The following is a description of a gene set: from publication Bucasas KL, Franco LM, Shaw CA, Bray MS, Wells JM, Niño D, Arden N, Quarles JM, Couch RB, Belmont JW (PMID 21357945) Human Gene Set: BUCASAS_PBMC_FLUARIX_FLUVIRIN_CAUCASIAN_MALE_AGE_18_40YO_HIGH_RESPONDERS_1DY_3DY_POSITIVE_PREDICTIVE_OF_TITER BACKGROUND: Annual vaccination is the primary means for preventing influenza. However, great interindividual variability exists in vaccine responses, the cellular events that take place in vivo after vaccination are poorly understood, and appropriate biomarkers for vaccine responsiveness have not been developed. METHODS: We immunized a cohort of healthy male adults with a licensed trivalent influenza vaccine and performed a timed assessment of global gene expression before and after vaccination. We analyzed the relationship between gene expression patterns and the humoral immune response to vaccination. RESULTS: Marked up regulation of expression of genes involved in interferon signaling, positive IL-6 regulation, and antigen processing and presentation, were detected within 24 hours of immunization. The late vaccine response showed a transcriptional pattern suggestive of increased protein biosynthesis and cellular proliferation. Integrative analyses revealed a 494-gene expression signature--including STAT1, CD74, and E2F2--which strongly correlates with the magnitude of the antibody response. High vaccine responder status correlates with increased early expression of interferon signaling and antigen processing and presentation genes. CONCLUSIONS: The results highlight the role of a systems biology approach in understanding the molecular events that take place in vivo after influenza vaccination and in the development of better predictors of vaccine responsiveness. studied in species Homo sapiens Genes positively correlated with titer response index in peripheral blood mononuclear cell in Caucasian male adults (18-40) (high responders) after exposure to Fluarix/Fluvirin, time point 1D and 3DY. Comment: Signature predictive of titer response index (TRI). Day 1 and day 3 values averaged., and this is the list of marker genes: STAT1, SPI1, IRF9, HLA-E, TNFSF13B, CD74